The following is a description of a gene set: studied in species Mus musculus Mouse Gene Set: GOBP_NEUTROPHIL_MEDIATED_KILLING_OF_FUNGUS The directed killing of a fungal cell by a neutrophil., and this is the list of marker genes: Ncf1, Pomc, Cxcl1, Elane, Arg1